The following is a description of a gene set: Human Gene Set: GOMF_INTRAMOLECULAR_OXIDOREDUCTASE_ACTIVITY studied in species Homo sapiens Catalysis of an oxidation-reduction (redox) reaction in which the hydrogen donor and acceptor are the same molecule, and no oxidized product appears., and this is the list of marker genes: ECH1, PTGDS, PDIA2, PTGES, HSD3B2 (NCBI Gene Id 3284), PTGIS, ECI1, TMX1, ERP27, PDILT, DCT, ECI2, GSTA1, PDIA5, ERP29, PDIA6, PDIA4, ENOX1, CYP2S1, IDI2, EHHADH, TXNDC5, CRELD2, HYI, ECHS1, FAHD2B, IDI1, SREBF2, CRELD1, HSD3B1, PDIA3, FAHD1, MRI1, DDTL, RPIA, PTGES2, HPGDS, GLRX2, PTGES3, EBPL, DDT, TBXAS1, TPI1, GPI, MIF, ERP44 (NCBI Gene Id 23071), QSOX1, FAHD2A, EBP, QSOX2, P4HB, MPI, TMX3, ITGB3